Given this list of marker genes HDAC3, PAX6, MAPRE1, SPRY2, PKHD1, SPRY1, GPSM1 (G protein signaling modulator 1), PAFAH1B1, ANKFN1, FBXW11 (F-box and WD repeat domain containing 11), CLASP1, CENPA, GJA1 (gap junction protein alpha 1), MISP, DYNLT1, INPPL1, ZW10, CDK5RAP2, ENKD1, MAD2L1, BCCIP, SPDL1, HTT, GPSM2, SAPCD2, DCTN1, CCDC66, UBXN2B, NSFL1C, PLK1, CLASP2, NDEL1, ESPL1, NUMA1, NUSAP1, KPNB1, ITGB1, NDC80, NDE1, MCPH1, KAT5, FGF10 (NCBI Gene Id 2255), here is a description of the gene set: The cell cycle process in which the directed movement of the mitotic spindle to a specific location in the cell occurs. Human Gene Set: GOBP_ESTABLISHMENT_OF_MITOTIC_SPINDLE_LOCALIZATION studied in species Homo sapiens